The following is a description of a gene set: species: Homo sapiens Pathway Definition from KEGG: (VHL*+RBX1+ELOC+ELOB+CUL2) // HIF1A == ARNT => (SLC2A1,VEGFA,TGFB,PDGFB,TGFA) Loss of VHL to HIF-1 signaling pathway. Pathway ID: N00080. Pathway type: Variant. Pathway class: nt06264 Renal cell carcinoma. Human Gene Set: KEGG_MEDICUS_VARIANT_LOSS_OF_VHL_TO_HIF_1_SIGNALING_PATHWAY, and this is the list of marker genes: VEGFA, SLC2A1, VHL, TGFA, RBX1, TGFB1, ELOC, HIF1A, CUL2, ARNT, TGFB2, ELOB, PDGFB, TGFB3